Given this list of marker genes DNTTIP2, WDR43, PUM3, REXO2, CD19, ART3, VRK2, PPP1CB, KDM2B, THEMIS2, DENND1B, MYBL1, RTCA, EML4, ZPR1, RRP1 (ribosomal RNA processing 1, NCBI Gene Id 8568), MYC, PACSIN3, UCHL5, ATAD3A, TRIP6, RRP1B, EEF1D, SLC11A2, GLMN, MTF2, POU2AF1, IGHM, CCL2, PIM2, SERBP1, KCNN4, OGG1, VPREB3, here is a description of the gene set: Up-regulated genes from the optimal set of 100 markers discriminating ER(-) breast cancer tumors by BRCA1 mutation status. from publication van 't Veer LJ, Dai H, van de Vijver MJ, He YD, Hart AA, Mao M, Peterse HL, van der Kooy K, Marton MJ, Witteveen AT, Schreiber GJ, Kerkhoven RM, Roberts C, Linsley PS, Bernards R, Friend SH (PMID 11823860) Breast cancer patients with the same stage of disease can have markedly different treatment responses and overall outcome. The strongest predictors for metastases (for example, lymph node status and histological grade) fail to classify accurately breast tumours according to their clinical behaviour. Chemotherapy or hormonal therapy reduces the risk of distant metastases by approximately one-third; however, 70-80% of patients receiving this treatment would have survived without it. None of the signatures of breast cancer gene expression reported to date allow for patient-tailored therapy strategies. Here we used DNA microarray analysis on primary breast tumours of 117 young patients, and applied supervised classification to identify a gene expression signature strongly predictive of a short interval to distant metastases ('poor prognosis' signature) in patients without tumour cells in local lymph nodes at diagnosis (lymph node negative). In addition, we established a signature that identifies tumours of BRCA1 carriers. The poor prognosis signature consists of genes regulating cell cycle, invasion, metastasis and angiogenesis. This gene expression profile will outperform all currently used clinical parameters in predicting disease outcome. Our findings provide a strategy to select patients who would benefit from adjuvant therapy. studied in species Homo sapiens Human Gene Set: VANTVEER_BREAST_CANCER_BRCA1_UP